The following is a description of a gene set: Human Gene Set: GOBP_COPII_COATED_VESICLE_CARGO_LOADING The formation of a macromolecular complex between the COPII coat proteins and proteins and/or lipoproteins that are going to be transported by the COPII vesicle to the Golgi. studied in species Homo sapiens, and this is the list of marker genes: TBC1D20, INSIG1, SEC24B, SEC24D, SEC24C, CIDEB, SEC13, RAB1A, SAR1B, SEC31A, SURF4, SEC23B, SEC31B, SAR1A, SEC24A, MIA3, SCAP, SEC23A